Given this list of marker genes PLCL1, DIRAS1, NOD2, RIPOR3, SULF1, FOXF1, STC1, CD44, SPOCD1, AMD1, CCDC85B, LHX4, ADAMTSL5, CADM1, TUBB2B (NCBI Gene Id 347733), GRIK4, FREM2 (NCBI Gene Id 341640), NECAB2, THBS1, CERS1, UGCG, IRS1, SULF2, ARTN, IL6ST, SEMA6A, CITED1, COL27A1, PLEKHG5, CTPS1, GAS6, ACOX2, CDT1, PPP4R4, SPINK4, KCTD6, SNHG15, KCNH1, NEIL2, PDCD2L, NCR3LG1, PXK, FLT4, NCF2, PSG9, LYAR, MBOAT1, NBL1, PUS7, CARD19, RUNX1, KCNF1, A4GALT, LY6E, TMEM229B, MAPT, BFSP2, CACNA1H, RBBP8, ZFPM2, CRACD, here is a description of the gene set: Human Gene Set: LI_ESTROGENE_T47D_E2_RESPONSE_UP As one of the most successful cancer therapeutic targets, estrogen receptor-alpha (ER/ESR1) has been extensively studied over the past few decades. Sequencing technological advances have enabled genome-wide analysis of ER action. However, comparison of individual studies is limited by different experimental designs, and few meta-analyses are available. Here, by ingesting large amount of E2-related transcriptomic data sets in breast cancer cell lines, we identified gene expression changes across 66 RNA-seq and 80 microarray experiments based upon the E2-induced fold change in gene expression. MCF7 and T47D cell lines have been used extensively as ER+ breast cancer models. However, extrapolation of this data to breast cancer is complicated by the known heterogeneity of breast cancer and potential biases arising from cell line-specific results. Importantly, while EstroGene contains transcriptomic data from 19 different breast cancer cell lines, data from MCF7 and T47D account for ~50% and ~20%, respectively, of all experiments. To characterize and describe contextual cell-line specific responses, we identified the top 10th percentile of upregulated and downregulated genes in an individual study and consistent among 50% of comparisons within MCF7 or T47D experiments. For non-MCF7/T47D experiments we lowered the threshold to 40% across studies due to the larger heterogeneity in this subset. Intersection of the three subsets yielded 89 and 96 uniquely regulated genes in MCF7 and T47D, we also identified genes that were not regulated in MCF7 and T47D but showed E2-induction in some other cell lines. species: Homo sapiens High confident estrogen up-regulated genes exclusively in T47D cells merged from 28 NGS datasets-based comparisons (10% topmost up-regulated genes and consistent in at least 50% comparisons). from publication Li Z, Li T, Yates ME, Wu Y, Ferber A, Chen L, Brown DD, Carroll JS, Sikora MJ, Tseng GC, Oesterreich S, Lee AV (PMID 37272757)